The following is a description of a gene set: Mouse Gene Set: GOBP_POSITIVE_REGULATION_OF_RIG_I_SIGNALING_PATHWAY studied in species Mus musculus Any process that activates or increases the frequency, rate or extent of RIG-I signaling pathway., and this is the list of marker genes: Usp15, Usp17le, Oasl1, Pum1, Trim15, Dhx58, Zcchc3, Pum2, Ankrd17, Zc3hav1, Ddx60